Given this list of marker genes POMP, KRT6A, KRT16, KRT17, KRT6B, here is a description of the gene set: Human Gene Set: HP_LINEAR_ARRAYS_OF_MACULAR_HYPERKERATOSES_IN_FLEXURAL_AREAS species: Homo sapiens Linear arrays of macular hyperkeratoses in flexural areas